The following is a description of a gene set: species: Homo sapiens Human Gene Set: HP_ATROPHIC_GASTRITIS Atrophic gastritis Atrophic gastritis (AG) is a histopathological entity that is characterized by chronic inflammation of the gastric mucosa with loss of gastric glandular cells and replacement by intestinal-type epithelium, pyloric-type glands, and fibrous tissue., and this is the list of marker genes: AIRE, NFKB1 (nuclear factor kappa B subunit 1), DEF6, CDH1, LRBA, CTLA4, IFIH1